The following is a description of a gene set: studied in species Homo sapiens Human Gene Set: KEGG_MEDICUS_REFERENCE_REGULATION_OF_COMPLEMENT_CASCADE_MAC_INHIBITION Pathway Definition from KEGG: (CD59,CLU,VTN) -| (C5b+C6+C7+C8+C9) Regulation of complement cascade, MAC inhibition. Pathway ID: N01505. Pathway type: Reference. Pathway class: nt06513 Complement cascade., and this is the list of marker genes: C8A, CD59, C8G (complement C8 gamma chain), C9, C7, C6, C8B, CLU, VTN